Given this list of marker genes KRAS, GRB2, ERBB2, PTPN12, HSP90AA1, ERBIN, HRAS, NRAS, SOS1, SHC1, CDC37, here is a description of the gene set: studied in species Homo sapiens Overexpression of ERBB2 (HER2), usually as a consequence of ERBB2 gene amplification, results in formation of ERBB2 homodimers. Under normal conditions, only ERBB2 heterodimers form, as ERBB2 is expressed at low levels.<br>ERBB2 homodimerization leads to activation of ERBB2 signaling in the absence of growth factors. Signaling by ERBB2 homodimers mainly activates the RAS/RAF/MAPK signaling cascade, while PI3K/AKT signaling is not significantly affected.<br>Trastuzumab (Herceptin), a recombinant antibody clinically approved as an anti-cancer therapeutic for ERBB2-overexpressing cancers, preferentially binds to ERBB2 homodimers.<br>Accurate functional analysis of ERBB2 signaling may require 3D instead of 2D cell culture. part of: Signaling by ERBB2 in Cancer Reactome Pathway: Constitutive Signaling by Overexpressed ERBB2